Given this list of marker genes Snhg20, Adipor2 (adiponectin receptor 2), Pdk3, Cdk4, Slc2a2, Ranbp1, Ldlr, Akr1c13, Plcb1, Cldn1, Ffar3, Ucp1, Zc3h12a, Oaz1, Irs1, Hmgcs2 (3-hydroxy-3-methylglutaryl-Coenzyme A synthase 2), Akr1c19, Akr1c12, Kcnk4, Srebf1, Ffar2, Pid1, Akr1c18, Lpl, Dgat2, Cpt1a, Id3, Pdk4, Ptafr, Zfp683, Nr1h4, Cav3, Cps1, Hes1, Kcnk2, Ass1, Or51e2, Nfatc4, Foxp1, Edn1, Ccl2, Smarcd1, Xrcc5, Src, here is a description of the gene set: Mouse Gene Set: GOBP_CELLULAR_RESPONSE_TO_FATTY_ACID species: Mus musculus Any process that results in a change in state or activity of a cell (in terms of movement, secretion, enzyme production, gene expression, etc.) as a result of a fatty acid stimulus.